The following is a description of a gene set: studied in species Mus musculus Mouse Gene Set: REACTOME_DEFENSINS Defensins, and this is the list of marker genes: Tlr2, Defb18, Defb14, Defa37, Defa5, Try10, Defa22, Prss1, Defa24, Defa21, Defa32, Defa42, Prss2, Defb42, Defa28, Defa31, Defa30, Defa26, Defa25, Defa20, Defb1, Defa41, Defa27, Defb25, Defa2, Tlr1, Defa23, Defb21, Try5, Defa36, Prss1l, Defb48, Defb19 (defensin beta 19), Ccr6, Art1, Defb28, Defa3, Prss3l, Defa43, Prss3, Defa38, Defa29, Defb4, Defa40, Defb47, Defb30, Defa17, Defb36, Try4, Defa35, Defb43, AY761185, Defa39, Defa34, Cd4